Given this list of marker genes NVL, EDN1, CCT7, RGPD1, CDK5RAP3, CHP1, TNPO3, SOX9, RGPD2, UBR5, TNPO1, TARDBP, MAPK14, WRAP53, TFRC, CARD10 (caspase recruitment domain family member 10), ECT2, SUN1, RPF2, RASSF5, ANGPT1, XPO1, BYSL, KPNA4, GLUL, RGPD3, KCNQ3, GLIS2, TCP1, NGFR, APPL2, EFCAB7, POLA2, NUP35, TRIM29, HEATR3, NR4A1 (nuclear receptor subfamily 4 group A member 1), YWHAB, CACNB4, EI24, KAT7, TAF8, RRP7A, MAVS, GLI3, FGF9 (NCBI Gene Id 2254), LMNA, MFHAS1, RANGAP1, FAM53A, ZBTB7A, SUMO1, TMEM201, NPAP1, DNAJB6, UTP25, WRN, NUP133, MEPCE, TOR1B, RRS1, IPO8, PPP1R10, HDAC3, PYGO1, RAP1GDS1, E2F3, PAF1, IFNG, NUP107, GCKR, CNEP1R1 (CTD nuclear envelope phosphatase 1 regulatory subunit 1), SYK, INS, CHP2, LATS1, UFM1, CSE1L, PPP3R1, NFKBIA, DCLK1 (doublecortin like kinase 1), ARL2BP, SIX3, RGPD6, SIX4, CCT8, XBP1, HEATR1, EIF2AK3, RANBP2, TGFB1, CDKN1A, CFL1, FERMT2, LMNB1, PPP3CA, DVL1, TSC2, PINX1, GBP2, FERMT1 (FERM domain containing kindlin 1), CCT6A, NUP58, PKIA, BRAT1, SUMO3, ZBTB16, SUMO4, PIK3R1, LEP, JUP, BMP4, ABCA7, MTOR, SIRT6, KPNA3, CCT5, TXN, TGFB2, TAF3, CTDNEP1, CTNNA1, TMCO6, CDK1, OTUD7B, POLR1A, TRAF3IP2, DCLK2, HYAL2, ATP13A2, SRSF1, CDK5, MBTPS1, ZIC1, POM121B, NUP88, BARD1, NR5A1, MSX1, TOR1A, CDH1 (cadherin 1), CD36, DMAP1, NPM1, ILRUN, SIN3A, APPL1, HHEX, HIKESHI, TERT, CREBBP, LRRK2, SKP1, INTS13, PARP1, MARK3, KPNA5, SMO, FAM76B (NCBI Gene Id 143684), PHB2, TBRG1, IPO9, EPM2A, BAG3, NUP153, TMEM98, SQSTM1, HDGF, NUP85, TESK1, MMP12, PLRG1, BCL3, RAB23, MAGED1, STK11, NUP54, DKC1, POM121L2, ATF2, TOPORS, POM121, SP100, FAM53B, MED1, YWHAZ, OSBPL8, CBLB, RANBP6, LARP7, TRIM28, PARP9, PRKD1, LMNB2, NUP98, CWH43, RANBP17, MDM2, IPO5, NOP53, IPO7, NOL8, TCF7L2, XPA (NCBI Gene Id 7507), IPO11, NOTCH1, PIK3R2 (phosphoinositide-3-kinase regulatory subunit 2), STK4, NF1, DCLK3, TPR, NMD3, NUP214, RPL23, COL1A1, FLNA, LATS2, SIX1, SMAD3, YAP1, PKIG, CHCHD10, NUP62, CCT2, ZC3H12A, EP300, NUTF2, CLDN18, HSP90AA1, SYNE1, PRKCD, DTX3L, TP53, HCLS1, HNRNPU (NCBI Gene Id 3192), CDKN2A, NUP93, LIMK2, MCRS1, PML, ING1, KPNA2, BBS4 (Bardet-Biedl syndrome 4), PTTG1IP, MDFIC, SEC13, PYHIN1, LILRB4, KPNB1, SHH, APOD, NUP155, MORC3, TOR1AIP2, KPNA7 (NCBI Gene Id 651469), CCT3, ZNF200, TNPO2, SUPT7L, IPO4, EIF4ENIF1, NF2, LZTS2, STK3, YWHAE, IL33, CCT4, SUFU, SIX2, PGR, ZPR1 (ZPR1 zinc finger), FAM53C, TXNIP, AKIRIN2, SPG11, PARK7, PIKFYVE, PPP3CB, ADAR, KPNA1, PRICKLE1, RGPD4, CABP1, TRIM40, ABRA, RPL11, SESN2, RBM22, SRC, ARL2, JAK2, CALR, SNUPN, LAMTOR5, RAN, GSK3B, CRY2, SPRN, F2, NUP188 (nucleoporin 188), NUAK2, PIN1, WWTR1 (WW domain containing transcription regulator 1), FYN, CIZ1, IPO13, PSEN1, TOR1AIP1, RPAIN, APP, CD2AP, SUN2, ELAVL1, ORMDL3, RGPD8, TMEM147, NUP50, AKT1, TYK2 (NCBI Gene Id 7297), STAT3 (signal transducer and activator of transcription 3), POM121C, TRIM8, PLK1, RGPD5, JAK1, FBXO4, DRD1, KPNA6, here is a description of the gene set: species: Homo sapiens Human Gene Set: GOBP_PROTEIN_LOCALIZATION_TO_NUCLEUS A process in which a protein transports or maintains the localization of another protein to the nucleus.